The following is a description of a gene set: Reactome Pathway: RNA Polymerase II Transcription Initiation studied in species Homo sapiens part of: RNA Polymerase II Transcription Initiation And Promoter Clearance Formation of the open complex exposes the template strand to the catalytic center of the RNA polymerase II enzyme. This facilitates formation of the first phosphodiester bond, which marks transcription initiation. As a result of this, the TFIIB basal transcription factor dissociates from the initiation complex.<p>The open transcription initiation complex is unstable and can revert to the closed state. Initiation at this stage requires continued (d)ATP-hydrolysis by TFIIH. Dinucleotide transcripts are not stably associated with the transcription complex. Upon dissociation they form abortive products. The transcription complex is also sensitive to inhibition by small oligo-nucleotides. <p>Dinucleotides complementary to position -1 and +1 in the template can also direct first phosphodiester bond formation. This reaction is independent on the basal transcription factors TFIIE and TFIIH and does not involve open complex formation. This reaction is sensitive to inhibition by single-stranded oligonucleotides., and this is the list of marker genes: POLR2A, POLR2K, TAF7, POLR2B, TBP, TAF3 (NCBI Gene Id 83860), TAF13, POLR2I, ERCC3, POLR2F, TAF1L, MNAT1, TAF9, TAF12, TAF6, CDK7, TAF11, GTF2H3, POLR2J, TAF5, GTF2H1, TAF8, POLR2G, TAF2, GTF2E2, TAF4B, CCNH, TAF15, POLR2L, GTF2E1, TAF4, GTF2A1, GTF2B, POLR2C, GTF2A2, GTF2H2, POLR2E, TAF1, GTF2F1, TAF7L, ERCC2, POLR2D, POLR2H, TAF9B, GTF2F2, GTF2H5, TAF10, GTF2H4